Given this list of marker genes TF, SLC25A39, TFR2, B2M, TFAP2A (transcription factor AP-2 alpha), BMP6, HFE, CCNB1, here is a description of the gene set: Any process that results in a change in state or activity of a cell (in terms of movement, secretion, enzyme production, gene expression, etc.) as a result of an iron ion stimulus. Human Gene Set: GOBP_CELLULAR_RESPONSE_TO_IRON_ION species: Homo sapiens